Given this list of marker genes SLC3A1, SLC7A13, SLC1A4, SLC7A11, SLC7A9, CTNS, here is a description of the gene set: Human Gene Set: GOBP_L_CYSTINE_TRANSPORT The directed movement of L-cystine (also known as dicysteine) into, out of or within a cell, or between cells, by means of some agent such as a transporter or pore. species: Homo sapiens